The following is a description of a gene set: Transcription regulation during the cell cycle is crucial for ensuring genes are expressed at the right time and in the correct amounts, coordinating key processes like DNA replication, mitosis, and cell division. In our study, Human Gene Set: PULVER_FOREY_CELLCYCLE_PEAKING_LG1 species: Homo sapiens Genes whose expression fluctuates during the cell cycle (pVal < 0.05) and peaks in late G1 (lG1) in K562, and this is the list of marker genes: NEXN, DRAM1, PPM1M, ZNF778, SLC49A4, NAGK, ZFHX2, RWDD2A, BIRC3, CYP4V2, SAMD9L, PDIA3, ZNF552 (NCBI Gene Id 79818), TAFA2, SELENOP, RAB38, HECW2, MUC4, SLC25A46, IGSF10 (NCBI Gene Id 285313), BMP8B (NCBI Gene Id 656), RNPC3, SLC9A2, CORO6, METTL21A, FSD1L, GPR137C, ZNG1F, MLYCD, TAS2R5, HERC4, SLC36A1, PNPLA7, ZNF208, KDM1B, MRAS, CDC26, ZNF490, ZNF563, IRS2, STX1B, KLHL28, HS2ST1, RNF103, C18orf32, JMJD7, AP3B2, GPR61, PLEKHA8, CCZ1B, TRIM26, ZNF430, CHRM4, TMEM263, WIPI1, KLHL15, CDNF, PRSS45P, ZNF84, TSPYL4, KIF13B, GALNTL6, CCNO, TAF13 (TATA-box binding protein associated factor 13), VSIG10, GPRIN1, CD83, ZNF514, PCBP4, ST3GAL5, ABHD18, ZDHHC1, SLC44A5, NXPE3, ROBO4, EIF2AK2, RIPK2, IL13RA1, ZMYND19, ABHD17C, ZNF846, ATP5IF1, EXOC3-AS1, DOK3, PLCB2, CCDC184, CARD6, LVRN (laeverin), B4GALT4, TM6SF1, ZNF841, CSPG5, MFSD8, MLEC, DIPK1A, CHCHD7, KHDC4, LIG4, NDUFC1, TPCN2, LPCAT4, MICOS10, SMPD1, APOA4, SGK3, SLC39A6, ARL4C, TLCD5, OSBPL2, LETM2, CILP, DHRS9, CPEB4, MBTPS2, ZNF69, NUAK2, IPMK, STARD5, GPRASP3, SLC15A2, NPTN, PLSCR2, SLC35E3, FBXO41, SPAG6, IMPACT, NOD1 (nucleotide binding oligomerization domain containing 1), LUZP1, STAP1 (NCBI Gene Id 26228), MED31, CLCN2, SMCR8, MMADHC, SLC29A4, DPY19L3, ISY1, ABCG2, ATG14, ZNF44, CYP26A1, LGR4, OSBPL7, RASA1, CD80, FAT2, RPL3L, SLCO1A2, ZBTB41, SRRM3, RHOQ, SDF2, ZNF789, RBM4, MOAP1, GPR158, GDF9, RDH14, PABPC4L, MITD1, MAGEC1, CCDC186, IZUMO1, CFAP210, SLC27A3, UPRT, VPS11 (VPS11 core subunit of CORVET and HOPS complexes), ARHGEF40, DIS3, C1orf198, SMIM8, DNAI4, FRK, ELMO2, RASGRP1, C10orf105, DMTF1, PPP1R3D, TENT5A, BMF, KLHL2, ITPKA, PAQR4, ANO7, UQCC6, CES3, SERINC1, NOTCH3, SFN, LRRC32, ENAH, UBE2V1, PGM3, HPS5, ZNF91, C9orf85, FAM222A, ANKRD42, PTGS1, MAGEC2, ST8SIA1, AKAP5, NR2C2AP, MAP2K3, DACT3, IL1R1, PPA2, B3GNT4, NRTN, TMEM38A, DYSF, ZNF397, MPPE1, FKBP9 (FKBP prolyl isomerase 9), YAE1, TMEM167A, ATP6V1C1, ZNF791 (zinc finger protein 791), IPPK, CASP3, AVIL, ERV3-1, SLC23A2, TMEM86A, DDX60L, TIMM10B, SETD9, ZNF845, WFS1, FAM114A1, ZNF341, EXOC3L4 (exocyst complex component 3 like 4), SP110, ODF2L, TANK, SLFN14, ARHGEF17, ECHDC3, FAM120C, CACNB3, ZNF345, FBXO33, NMU, PIK3R1, FASTKD3, DLG2, ZNF254, PPP1R16B, CAPN7, SAR1A, CCDC126, ZDBF2, RMND1, MAGEH1, FEZ2, NPL, TOGARAM1 (TOG array regulator of axonemal microtubules 1), BRSK2, RBM43, BICDL1, ZNF417, PCDHGA2, STK31, ATP6V1H, IFNGR2, GORAB, IFNGR1, PEX2, LYVE1 (NCBI Gene Id 82367), SLC31A1, CYB5A, PTK7, SPMIP8, LY6G5B, TDRD7, MEIS1, RPRD1A, ZBTB47, PCYOX1 (prenylcysteine oxidase 1), SCARB2, MAP9, PCDH1, ZNF34, GYPB, RNASEL, TCF7L2, ZC3HAV1, PHTF1, GLMN, NAPG, ZNF347, CERT1, TSPAN15, PRXL2C (peroxiredoxin like 2C), ZNF687-AS1, ZNF136, IL18BP, IL12RB2, TMX3, RO60, ZNF396, BEND2, GOLT1B, DUSP3, ZNF629, OTX1, ZNF599, ZNF66, ZNF527, TTPAL, NABP1, CHPF2, ZNF736, MYORG, ALG10B, FICD, GFI1B, WHAMM, AZIN2, KCNT2, XKR3, HOXD8, REL, ZBTB49, TSGA10, ALKBH6, IL18, LAMP1, SNRPB2, MIP (major intrinsic protein of lens fiber), GPR146, KREMEN2, G3BP2, SLC25A16, IMPA1, LRRC20, TMEM144, SMARCA1, PIK3R4, ZNF354B, MPP3, FAM8A1, GET1, LTB4R, ST20, SCG2, PTBP2, ITGB1BP2, ANKMY2, UNC119, ZNF675, TPMT, C6orf163, PREX2, ZNF200, TSPAN13, CYTH1, IGSF11, RUNDC3A, ZNF334, FNBP1L, PACSIN1, MAP3K13, SLC66A3, PNPLA4, GVQW3, UNG, ECT2L, RAB40B, PDP1, NPC1L1, TICAM2, ZMYM5, ACBD5 (acyl-CoA binding domain containing 5), GK5, TXNL4B, HILPDA, TMEM87B, LDAF1, KIN, ACADSB, AMZ2, GRK4, CASD1